The following is a description of a gene set: Human Gene Set: HP_TALL_STATURE Tall stature A height above that which is expected according to age and gender norms. species: Homo sapiens, and this is the list of marker genes: HRAS, CIC, HSPG2, UPF3B, PIGL, FOS, HEY2, FAM20A, TXNRD2, SMS, AGPAT2, DIS3L2, TGFB1, RTL1, FARSB, TUBB4A, SRY, TPM3, SUZ12, FGF3, C1R, SMAD2, NFIX, MED12, NSDHL, LRP4, ZNF469, TNNT1, THSD4 (thrombospondin type 1 domain containing 4), FIBP, CAMK2A, ESR1, NNT, ABAT, CDKN1A, CAVIN1, TCF20, MAT2A, LETM1, BSCL2, FBN2, DNMT3A, SPIN4, RNF135 (ring finger protein 135), GLI3, EED, MYH11, CDKN1B, FOXE3, NKAP, HECTD4, TRIM32, PRKAR1A, PTEN, PIK3R2 (phosphoinositide-3-kinase regulatory subunit 2), MYPN, CHD8 (chromodomain helicase DNA binding protein 8), GPR101, EHMT1, FBN1, EFEMP2, LARS2, SOST, KCNQ1OT1, POLR3A (NCBI Gene Id 11128), CDKN2B, NPR3, EFEMP1, MYLK, HERC1, NRAS, NELFA, MEG3, KLHL41, PTCH1, RAB23, KIF7, AR, ACTA2, SMAD3, HNRNPK, PIGG, YWHAE, CTBP1, MRAP, SLC6A8 (NCBI Gene Id 6535), PLOD1 (NCBI Gene Id 5351), COL6A1, MC4R, ARHGEF9, CYP19A1, KANSL1, AIP, GRIA3, APC2, FBLN5, IPO8, PIGA, LOX, CBS, PYROXD1, POR, MC2R (melanocortin 2 receptor), SMAD4, TGFBR1, SPTAN1, DLG4, PAFAH1B1, DSE, ATP6V1E1, COL1A2, CCND1, SUFU, TGFB2, EZH2, DICER1, COL2A1, PRKG1, CPLX1, FBXO11, MEGF8, POLG, H3-3B, TGFB3, PDE11A, AKT1, IGF2, RET, STRADA, KBTBD13, SETD2, GPC4, FKBP14, STAR, TYMP, SHANK3, HPGD, AGGF1, NF1, MEN1, TAF4, MFAP5, NSD2, ZDHHC9, CHST14, KMT2C, LHCGR, ELN, PPARG, MTM1, ASXL3, PIK3CA, ATP6V1A, SRRM2, NPR2, NONO, BMP4 (NCBI Gene Id 652), TIMM50, WRN (WRN RecQ like helicase), FGFR3, KCNQ1, CNOT1, DNA2, NSD1, TPM2 (tropomyosin 2), TGFBR2, CAV1, ACTA1, CDKN2C, KRAS, DLK1, MAN2B1, RERE, PDGFRB, NEB, GPC3 (glypican 3), CDKN1C (NCBI Gene Id 702), SARS1